Given this list of marker genes NUP62, KNSTRN, IL12RB2, STOM, ERMN, BLMH, IL10, FHL2, NUP93, HMOX1, RPP25L, SMC6, RAD51AP1, TUFT1, GNB4, BRIP1, PRICKLE1, TPI1, OSBPL9, IQGAP3, BLM, CASP7, SLC25A10, UBE2T, ADAP1, MYBL1, EPDR1, CMC2 (C-X9-C motif containing 2), CPD, THOC6, PTGIR, PSMD13, DEPDC1B, SHC4, FAM81A, TPBG, VASH1, HMMR, CARHSP1, BMP2K, ACTG1, SLC12A8, EHBP1L1, KIF18B, CCDC18, PRICKLE3, PRELID2, TYMS, EIPR1, ELF4, ORC6, UBR7, CYB5B, FUT4, GPR25, KDM2B, CA13, NSMAF, UBXN8, WDR62, RAB6A, SRSF12, GLRX, INTS7, ABCC4, DUSP4, HMGB3, KLHDC2, PDSS1, NUCB1, PSMD14, SRGN, FOXM1, POLH, CARNMT1, GCNT1, GSR, TMPO, ARHGAP19, CDKN1A (NCBI Gene Id 1026), BCAT1, SH3RF1, BEND4, STIL, TUBE1, ANXA7 (annexin A7), SELENOH, IFIH1, G2E3, SERPINF1, CENPN, BCL3, RPA1, FAXC, SMTN, ZBTB32, EXPH5, PMVK, PMCH, ESM1, RORC, PRELID3B, GPD2, ANGPTL2, FAM111A, KIF20B, MELK, STAU2 (NCBI Gene Id 27067), SOD1, CEP83 (NCBI Gene Id 51134), GTSF1, FBXO5, FKBP2, PYCARD, LGALS1, AMDHD2, UBASH3B, SPRED1, KLC3, STK39, TNFRSF9, MMD, ATP1A2, DSP, ICA1, TUBB3, H2AX, CDK2AP1, RAF1, FIGNL1, LCLAT1, PASK, DAP, TIMP2, ACER3, HMCES, NELFE, RBM44, ANAPC15, NPLOC4, IL1R2, TREX1 (three prime repair exonuclease 1), GCG, LRR1, GARS1, BUB1, RCC1, MAPRE2, DUSP14, MMP16, SEMA4C, E2F8, INCENP (inner centromere protein), FMR1, PCNA, CYP11A1, FAM156A, CD81, HIF1A, GINS2, HMGN3, CHEK1, DNA2, SNRNP25, LITAF, EHD4, APIP, CIT, RAPGEF5, RPA2, EXO1 (exonuclease 1), GPAT3, NHSL3, SLC25A20, MTCH1, UBR5, PIF1, RTCA, SH2D2A, ANKRD50, TRIP12, CLIC4, FRMD4B, CKAP2L, CYTH2, UBL4A, EIF4H, POC1A, DERL2 (derlin 2), ERBB3, LSM2 (LSM2 homolog, U6 small nuclear RNA and mRNA degradation associated), POLE, CDC25C, KIF18A, GSTM5, CBFB, MAP2K3, FARP1, CDC45, TOX2, here is a description of the gene set: Much is known concerning the cellular and molecular basis for CD8+ T memory immune responses. Nevertheless, conditions that selectively support memory generation have remained elusive. Here we show that an immunization regimen that delivers TCR signals through a defined antigenic peptide, inflammatory signals through LPS, and growth and differentiation signals through the IL-2R initially favors antigen-specific CD8+ T cells to rapidly and substantially develop into tissue-residing T effector-memory cells by TCR transgenic OVA-specific OT-I CD8+ T cells. Amplified CD8+ T memory development depends upon a critical frequency of antigen-specific T cells and direct responsiveness to IL-2. A homologous prime-boost immunization protocol with transiently enhanced IL-2R signaling in normal mice led to persistent polyclonal antigen-specific CD8+ T cells that supported protective immunity to Listeria monocytogenes. These results identify a general approach for amplified T memory development that may be useful to optimize vaccines aimed at generating robust cell-mediated immunity. Gene expression analysis was performed for OT-I T cells on day 3 and day 5 after activation with ovalbumin and LPS in vivo with and without treatment with IL-2 using an agonists IL-2/anti-IL-2 complexes (IL2/Jes-6.1) Human Gene Set: GSE39110_UNTREATED_VS_IL2_TREATED_CD8_TCELL_DAY3_POST_IMMUNIZATION_DN studied in species Homo sapiens Genes down-regulated in CD8 T cells 3 days after immunization: control versus IL2 treatment. from publication Castro I, Dee MJ, Malek TR (PMID 23018461)